Given this list of marker genes PSG1, SPRYD7, SEMG2, TAS2R1, LMAN1, ZFYVE16, SPRY4, LIPC, PAX5, RFPL3, BEX1, PMAIP1, CCDC102B, TBX2, HSD17B8, TMOD1, SLC25A24, TFR2, GBX1, EPYC, MYH7, PRRG3, FBP2, FLRT3, CDH18, KCNE1, COX11, CELA3A (NCBI Gene Id 10136), IL17A, CDON, CCL11, APLNR, HMGCS2, RPH3A, CHN2, CCL18, EXOC6B, MYCNOS, SLC26A3, DKK2, CFHR5, PEX2, WRNIP1, IMPA1, ZBTB32, AMPD1, SDCBP, GPR4, NLGN1, CLSTN2, THPO (NCBI Gene Id 84434), SERPINI1, RAMP2, NPHS2, PNP, S100G, PYGO1, CTSF, AFM, RASSF8, PCOLCE2, TNFAIP8, RUNX2, SLCO1C1, FCN2, H3C7, DERA, HSD3B2, TREML2, CETN3, GNG13, ACADL, CHMP4A, HTR4, CMAS, CNR1, PLAC1, ZNF287, UTP18 (UTP18 small subunit processome component), ABCD3, PIP (NCBI Gene Id 5304), MCF2L-AS1, TCEAL2, COL6A2, RPA4, GSG1, MATN3, GPN3, ANKRD40, ADGRG3, LINC00574, CSE1L, RLBP1, KCNJ8, CDK5R2, NSUN3, FBXO4, CYP11B1, SORCS3, MATN4, LYRM1, GRIA2, HOXA11, MAGEA3, DKK4, ISOC1, GSTM5, STARD8, GTF3A, NDUFB3, ASCL1, PDCD10, P2RX5, FAM90A1, SPTB, ARL4A, CTSL, SLC4A1, DDT, KANSL3, PROM1, RARB, POLR1F, TARP, CRYZL1, METTL4, ENOPH1, EPHB1, DHFRP3, SDHD, GNL1, PPP2R3C, PSMD10, TAL1, ZNF267, MIA2, HPRT1, OR12D2, COL5A3, TMEM262 (NCBI Gene Id 399904), PGAM2, ARHGEF38, CATSPERG, NOS2, DIPK2B, GH1, ABHD5, ACTR3B, TRIM15 (tripartite motif containing 15), P2RY14, KLF3-AS1, RNF17, IQGAP2, EBAG9, CHORDC1, GJA4, ADRB3, FOLR3 (folate receptor gamma), G6PC1, NFKBIB, CD27, OCM2, VTN, SLCO1A2, TMPRSS6, MOXD1, KIN, SNRNP27, QPCTL (glutaminyl-peptide cyclotransferase like), CUZD1, PGGT1B, NCF1C, GCA, TMOD3 (NCBI Gene Id 29766), PLVAP, BCS1L, ACTL7B, MTNAP1, DNAJA4, ABCA4, RAB4A, BMP15, SLC2A5, ATP5IF1, HAPLN1, HAND2-AS1, KALRN, CD80, PRR34, TMEM243, CACNA1S, OLFML2B, CTBS, SCUBE3, KLK15, MOSPD1, PIGH, here is a description of the gene set: Human Gene Set: GSE18281_SUBCAPSULAR_CORTICAL_REGION_VS_WHOLE_MEDULLA_THYMUS_DN from publication Griffith AV, Fallahi M, Nakase H, Gosink M, Young B, Petrie HT (PMID 20064453) species: Homo sapiens Genes down-regulated in thymus subcapsular cortical region versus the whole medulla. Interaction of hematopoietic progenitors with the thymic stromal microenvironment induces them to proliferate, adopt the T cell fate, and asymmetrically diverge into multiple T lineages. Progenitors at various developmental stages are stratified among different regions of the thymus, implying that the corresponding microenvironments differ from one another, and provide unique sets of signals to progenitors migrating between them. The nature of these differences remains undefined. Here we use novel physical and computational approaches to characterize these stromal subregions, distinguishing gene expression in microdissected tissues from that of their lymphoid constituents. Using this approach, we comprehensively map gene expression in functionally distinct stromal microenvironments, and identify clusters of genes that define each region. Quite unexpectedly, we find that the central cortex lacks distinctive features of its own, and instead appears to function by sequestering unique microenvironments found at the cortical extremities, and modulating the relative proximity of progenitors moving between them.